The following is a description of a gene set: Human Gene Set: GOBP_RESPONSE_TO_CYCLOHEXIMIDE studied in species Homo sapiens Any process that results in a change in state or activity of a cell or an organism (in terms of movement, secretion, enzyme production, gene expression, etc.) as a result of a cycloheximide stimulus. Cycloheximide (actidione) is an antibiotic produced by some Streptomyces species which interferes with protein synthesis in eukaryotes., and this is the list of marker genes: KLF4, CDA, BORCS7, XRN1, GHR, KLF2, BCL2L1